The following is a description of a gene set: Any process that activates or increases the frequency, rate or extent of actin depolymerization. Human Gene Set: GOBP_POSITIVE_REGULATION_OF_ACTIN_FILAMENT_DEPOLYMERIZATION studied in species Homo sapiens, and this is the list of marker genes: CARMIL2, WDR1, ACTN2, DSTN, PDXP, VIL1, PLEK, CFL2, SEMA5A, WASHC2C, CFL1 (NCBI Gene Id 1072), CRACD (NCBI Gene Id 57482), CARMIL1, F2RL1